Given this list of marker genes UGDH, HS3ST2, EXT1, HS3ST3A1, CLTC, XYLT1, CHPF2, CHSY1, B3GAT2, PDGFB, B3GALT6, TGFB1, HAS1, EXT2, HAS2 (NCBI Gene Id 3037), AP2A1, IGF1, GALNT5, EGF, NFKB1, ABCC5, CHST3, CHST11, HS3ST3B1, PXYLP1, SLC35B2, CHST12, CSGALNACT1, CHSY3, CYTL1, CHST13, SMPD3, CEMIP, B3GAT1, IL1B, B3GAT3, GCNT2, B4GALT7, HS3ST1, CSGALNACT2, CHPF, CHST7, HAS3, XYLT2, HEXA, here is a description of the gene set: species: Homo sapiens Human Gene Set: GOBP_GLYCOSAMINOGLYCAN_BIOSYNTHETIC_PROCESS The chemical reactions and pathways resulting in the formation of glycosaminoglycans, any one of a group of linear polysaccharides composed of repeating disaccharide units.